Given this list of marker genes IL18RAP, MYBL1, GNLY, STAT4, CD96, CST7, S1PR5, KIR2DS5, CCL5, KIR2DL2, NKG7, KLRB1, CD244 (CD244 molecule), KIR2DS1, TBX21, KIR3DL3, KLRF1, PTGDR, RORA, ADGRG1, HOPX, GZMA, GIMAP7, KLRK1 (killer cell lectin like receptor K1), KIR3DL1, SH2D2A (SH2 domain containing 2A), CD7, KIR2DL5A, PRF1, KLRC1, KIR2DL3, GZMM, SAMD3, IL2RB, CLIC3, ARL4C, TGFBR3, KIR2DL1, KLRD1, KIR2DS2, GZMB, PVRIG, GZMH, CD247, KIR2DL4, ZAP70, XCL2, PRKCQ, KIR2DS3, here is a description of the gene set: Genes negatively correlated with protection in peripheral blood mononuclear cell in unknown after exposure to P. falciparum RTS,S/AS01, time point 56D RTS,S is an advanced malaria vaccine candidate and confers significant protection against <i>Plasmodium falciparum</i> infection in humans. Little is known about the molecular mechanisms driving vaccine immunity. Here, we applied a systems biology approach to study immune responses in subjects receiving three consecutive immunizations with RTS,S (RRR), or in those receiving two immunizations of RTS,S/AS01 following a primary immunization with adenovirus 35 (Ad35) (ARR) vector expressing circumsporozoite protein. Subsequent controlled human malaria challenge (CHMI) of the vaccinees with <i>Plasmodium</i>-infected mosquitoes, 3 wk after the final immunization, resulted in ~50% protection in both groups of vaccinees. Circumsporozoite protein (CSP)-specific antibody titers, prechallenge, were associated with protection in the RRR group. In contrast, ARR-induced lower antibody responses, and protection was associated with polyfunctional CD4<sup>+</sup> T-cell responses 2 wk after priming with Ad35. Molecular signatures of B and plasma cells detected in PBMCs were highly correlated with antibody titers prechallenge and protection in the RRR cohort. In contrast, early signatures of innate immunity and dendritic cell activation were highly associated with protection in the ARR cohort. For both vaccine regimens, natural killer (NK) cell signatures negatively correlated with and predicted protection. These results suggest that protective immunity against <i>P. falciparum</i> can be achieved via multiple mechanisms and highlight the utility of systems approaches in defining molecular correlates of protection to vaccination. Human Gene Set: KAZMIN_PBMC_P_FALCIPARUM_RTSS_AS01_AGE_UNKNOWN_CORRELATED_WITH_PROTECTION_56DY_NEGATIVE species: Homo sapiens from publication Kazmin D, Nakaya HI, Lee EK, Johnson MJ, van der Most R, van den Berg RA, Ballou WR, Jongert E, Wille-Reece U, Ockenhouse C, Aderem A, Zak DE, Sadoff J, Hendriks J, Wrammert J, Ahmed R, Pulendran B (PMID 28193898)